Given this list of marker genes ORMDL2, SAMD8, ZNF750, SPHK1, ABCA2, PRKCD, ORMDL1, SPHK2, CCN1, PRKAA1, ENPP7, SIRT3, ORMDL3, PLA2G6, PAQR4 (progestin and adipoQ receptor family member 4), here is a description of the gene set: Human Gene Set: GOBP_REGULATION_OF_SPHINGOLIPID_BIOSYNTHETIC_PROCESS Any process that modulates the rate, frequency or extent of sphingolipid biosynthesis. Sphingolipid biosynthesis is the chemical reactions and pathways resulting in the formation of sphingolipids, any of a class of lipids containing the long-chain amine diol sphingosine or a closely related base (a sphingoid). species: Homo sapiens